Given this list of marker genes TGFB2, CASP6, GJA1, FDFT1, BMP2, GADD45A, CAV1, PERP, WNT5A, PLAU, GTF2H4, DUT, DPYD, CCNB2, MARS1 (methionyl-tRNA synthetase 1, NCBI Gene Id 4141), ABL1, IGFBP2, FGF7, MYD88, DCN, SPTAN1, IL1B, PNP, CCNE2, DAPK1, GTF2H5, TNFRSF10A, BIRC3, TIMP3, HMGCR, GSTO1, BTG3, CFLAR, WEE1, CREBBP, ERBB2, IRF6, IFNA10, CXCL8, IL6, CDH1, FEN1, BHMT, TNFRSF10B, ERCC1, IL1R1, GPX3, SMAD4, HGF (hepatocyte growth factor), CDKN1B, PDGFRB, RNASEL, HSP90AA1, RTP4, BGN, RAD23B, MGMT, IGFBP7, POLB, GSTM1, IFNGR1, FAS, TIMP2, IGF2R, RHOB, LUM, ERBB3, GSTP1, HSPB1, MAP3K9, TANK, PTEN, SHC3 (SHC adaptor protein 3), BAX, PDGFRA, TNFSF10, TLR3, IGFBP3, GSR, BTG2, IL1A, VTN, PRKACB, SMAD1, UMPS, MMP2, MAT2B, BID, MTR, MAP3K1, TIMP1, POLG, CCNB1, CASP7, YWHAQ, BORCS8, TRADD, AK4, TP53, SMAD7, SC5D, CCNE1, FZD1, FANCG, EGR3, CASP1, LITAF, BRCA1, EREG, CDK2, SHC1, CASP3, DCTD, PLAUR, PLAT, JUN, IL6ST, MGST2, CDKN1A, CDC25A, CDKN2B, POLR2E, CDK1, FGF11, NFKBIA, IDI1, TNFRSF12A, SKIL, APAF1, POLQ, here is a description of the gene set: Human Gene Set: KOKKINAKIS_METHIONINE_DEPRIVATION_48HR_UP Genes up-regulated in MEWO cells (melanoma) after 48h of methionine deprivation. from publication Kokkinakis DM, Brickner AG, Kirkwood JM, Liu X, Goldwasser JE, Kastrama A, Sander C, Bocangel D, Chada S (PMID 16908595) species: Homo sapiens Methionine deprivation stress (MDS) eliminates mitotic activity in melanoma cells regardless of stage, grade, or TP53 status, whereas it has a negligible effect on normal skin fibroblasts. In most cases, apoptosis accounts for the elimination of up to 90% of tumor cells from the culture within 72 hours after MDS, leaving a scattered population of multinucleated resistant cells. Loss of mitosis in tumor cells is associated with marked reduction of cyclin-dependent kinase (CDK) 1 transcription and/or loss of its active form (CDK1-P-Thr(161)), which is coincident with up-regulation of CDKN1A, CDKN1B, and CDKN1C (p21, p27, and p57). Expression of the proapoptotic LITAF, IFNGR, EREG, TNFSF/TNFRSF10 and TNFRSF12, FAS, and RNASEL is primarily up-regulated/induced in cells destined to undergo apoptosis. Loss of Aurora kinase B and BIRC5, which are required for histone H3 phosphorylation, is associated with the accumulation of surviving multinucleated cells. Nevertheless, noncycling survivors of MDS are sensitized to temozolomide, carmustin, and cisplatin to a much greater extent than normal skin fibroblasts possibly because of the suppression of MGMT/TOP1/POLB, MGMT/RAD52/RAD54, and cMET/RADD52, respectively. Sensitivity to these and additional genotoxic agents and radiation may also be acquired due to loss of cMET/OGG1, reduced glutathione reductase levels, and a G(2)-phase block that is a crucial step in the damage response associated with enhancement of drug toxicity. Although the genes controlling mitotic arrest and/or apoptosis in response to low extracellular methionine levels are unknown, it is likely that such control is exerted via the induction/up-regulation of tumor suppressors/growth inhibitor genes, such as TGFB, PTEN, GAS1, EGR3, BTG3, MDA7, and the proteoglycans (LUM, BGN, and DCN), as well as the down-regulation/loss of function of prosurvival genes, such as NFkappaB, MYC, and ERBB2. Although MDS targets several common genes in tumors, mutational variability among melanomas may decide which metabolic and signal transduction pathways will be activated or shutdown.